The following is a description of a gene set: Human Gene Set: REACTOME_ACTIVATION_OF_NIMA_KINASES_NEK9_NEK6_NEK7 species: Homo sapiens Activation of NIMA Kinases NEK9, NEK6, NEK7, and this is the list of marker genes: PLK1, CDK1, NEK6, CCNB2 (NCBI Gene Id 9133), CCNB1, NEK9, NEK7